Given this list of marker genes MCM8, ORC2, CCNB1, ORC4, ORC5, ORC1, ORC3, ORC6, CDK1, here is a description of the gene set: species: Homo sapiens Under specific conditions, Cyclin B, a mitotic cyclin, can inhibit the functions of pre-replicative complex. E2F1 activates Cdc25A protein which regulates Cyclin B in a positive manner. Cyclin B/Cdk1 function is restored which leads to the disruption of pre-replicative complex. This phenomenon has been demonstrated by Bosco et al (2001) in Drosophila. part of: E2F mediated regulation of DNA replication Reactome Pathway: E2F-enabled inhibition of pre-replication complex formation